Given this list of marker genes CBL, PFKFB2, IL13RA1, BCL2L11, DUSP4, here is a description of the gene set: Human Gene Set: LIU_IL13_MEMORY_MODEL_DN Genes down-regulated in BEAS-2B cells (bronchial epithelium) stimulated with IL13 on days 1 to 3 and then rested for the next 3 days (repeated-stimulation or memory model) species: Homo sapiens Our objective was to establish an experimental model of a self-sustained and bistable extracellular signal-regulated kinase 1/2 (ERK1/2) signaling process. A single stimulation of cells with cytokines causes rapid ERK1/2 activation, which returns to baseline in 4 h. Repeated stimulation leads to sustained activation of ERK1/2 but not Jun N-terminal protein kinase (JNK), p38, or STAT6. The ERK1/2 activation lasts for 3 to 7 days and depends upon a positive-feedback mechanism involving Sprouty 2. Overexpression of Sprouty 2 induces, and its genetic deletion abrogates, ERK1/2 bistability. Sprouty 2 directly activates Fyn kinase, which then induces ERK1/2 activation. A genome-wide microarray analysis shows that the bistable phospho-ERK1/2 (pERK1/2) does not induce a high level of gene transcription. This is due to its nuclear exclusion and compartmentalization to Rab5+ endosomes. Cells with sustained endosomal pERK1/2 manifest resistance against growth factor withdrawal-induced cell death. They are primed for heightened cytokine production. Epithelial cells from cases of human asthma and from a mouse model of chronic asthma manifest increased pERK1/2, which is associated with Rab5+ endosomes. The increase in pERK1/2 was associated with a simultaneous increase in Sprouty 2 expression in these tissues. Thus, we have developed a cellular model of sustained ERK1/2 activation, which may provide a mechanistic understanding of self-sustained biological processes in chronic illnesses such as asthma. from publication Liu W, Tundwal K, Liang Q, Goplen N, Rozario S, Quayum N, Gorska M, Wenzel S, Balzar S, Alam R (PMID 20123980)